Given this list of marker genes RAD21, KATNA1, MACIR, CDK5RAP2, PTPRJ, PABPC5, MOSMO, LACTB2, PEAK1, COBL, MFAP3L, PDZK1, DFFB, CREBRF, CEP44, TRIM33, CYP7A1, COPS8, HHAT, CLCC1, CLSTN2 (calsyntenin 2), PPP1R2, CCL20, PDE8A, VSTM2A, PRB3, PLXDC2, KLF13, CNGB1, CSMD3, P3H1 (NCBI Gene Id 64175), CROT, NEURL1B, MLLT3, PCDHGA11, SEC22C, KLHL36, ABHD2, SH3TC2, PABIR3, PPM1A, NPY2R, GPC6, LSM8, TRIM38, DYNLT1, ANKRD27, CLOCK, REPS1, IGSF10, CCL28, CISD2, SPOCK3, CHMP5, TXNDC9, NALCN, LYSET, ME1, TAOK1, ABI1, EYS, COL4A4, OGN, LYN, CHL1, TUBB6, TMEM200B, SPINK8, NPNT, URI1, TOPORS, KITLG, MED23, GLMN, CDKN2AIP, ZNF407, NUP160, PRB1, RNFT2, here is a description of the gene set: Genes predicted to be targets of miRBase v22 microRNA hsa-miR-15b-3p in miRDB v6.0 with MirTarget v4 prediction scores > 80 (high confidence targets). Human Gene Set: MIR15B_3P from publication Chen Y, Wang X (PMID 31504780) studied in species Homo sapiens